Given this list of marker genes Il18, Ccr2, Irf1, Klhl25, Mir326, Opa1, Ccl20, Runx1, Ada, Mir301, Syk, Sash3, Brd4, Shh, Tgfb1, Brd2, Zfp683, Ripk2, Lilrb4a, Il4ra, Socs5, Rara, Foxp3, Anxa1, Prkcz, Gli3, Malt1, Il4, Ccl19, Il2rg, Il6, Hlx, Tbx21, Pf4, Loxl3, Cbfb, Ap3d1, Gimap3 (GTPase, IMAP family member 3), Ap3b1, Zbtb7b, Socs1, Nfkbid, Zc3h12a, Zap70, Ifng, Cd69, Zfp35, Il27, Tgfbr2, Rc3h1, Runx3, Sh3rf1, Tnfsf4, Ccr7, Prdm1, Smad7 (SMAD family member 7), Kcnk18, Lgals1, Il2, Nlrp3, Il23a, Gimap5, Pnp, Ankle1, Hmgb1, Rc3h2, Tnfsf18, Nckap1l, H2-Ea, Ep300, Ccr6, Ihh, Ascl2, Slc4a2, Rhoa, Shb, Nfkbiz, Jak3, Cd1d1, Bcl6, Nkap, Cd83, Itpkb, Lilrb4b, Gata3, here is a description of the gene set: studied in species Mus musculus Any process that modulates the frequency, rate or extent of alpha-beta T cell differentiation. Mouse Gene Set: GOBP_REGULATION_OF_ALPHA_BETA_T_CELL_DIFFERENTIATION